The following is a description of a gene set: studied in species Homo sapiens Maturation of monocyte-derived dendritic cells (DC) in response to inflammatory stimuli: genes up-regulated both at 8 hr and 48 hr after the stimulation (cluster B). Maturation of dendritic cells (DC) serves a deterministic role in the link between innate and adaptive immunity, constituting a checkpoint with regard to whether responses from the lymphocyte compartment shall be raised and what class of response is needed to protect the host against invading pathogens. Since DC have not been shown to possess mechanisms such as gene recombination or somatic mutation for generating a diverse repertoire of antigen-recognition receptors, it is unlikely that these leukocytes can intrinsically respond to all conceivable molecules present in our environment. In the present study, we have therefore determined how mediators of the inflammatory response regulate global gene transcription in DC. The data represent an extensive and time-ordered reprogramming of the DC during their course of maturation, involving genes encoding proteins that regulate responses of both innate cells and lymphocytes. This transcriptional reorganization may reflect the effect of in vivo released inflammatory mediators induced by endogenous or pathogenic stimulation. from publication Lindstedt M, Johansson-Lindbom B, Borrebaeck CA (PMID 12356685) Human Gene Set: LINDSTEDT_DENDRITIC_CELL_MATURATION_B, and this is the list of marker genes: TNIP1, JRK, NR4A3, PSME2, GADD45A, PLA2G6, USP12, EED, CXCR4 (C-X-C motif chemokine receptor 4), CYTIP, OPTN, SIAH2, TRAF1, BTG1, NFKB2, MARCKS, LAMP3, NBN, NFKB1, PNRC1, HIVEP1 (NCBI Gene Id 3096), LYN, MAP3K14, ZNF267, DUSP4, TNFRSF9, ID2, STK4, TAP1, TNFAIP3, SLAMF1, SDC4, PALM2AKAP2 (PALM2 and AKAP2 fusion), IL15RA, BIRC3, MARCKSL1, IL2RA, ADM, PDGFA, NFKBIA, RELB, N4BP2L2, KLF5, CD83, REL, CSF2RA, CD80, CFLAR, TNFAIP2